The following is a description of a gene set: from publication Delacroix L, Moutier E, Altobelli G, Legras S, Poch O, Choukrallah MA, Bertin I, Jost B, Davidson I (PMID 19884340) Mouse Gene Set: DELACROIX_RAR_BOUND_ES species: Mus musculus Genes with DNA sequences bound by RARA and RARG in ES cells. All-trans retinoic acid (RA) induces transforming growth factor beta (TGF-beta)-dependent autocrine growth of mouse embryonic fibroblasts (MEFs). We have used chromatin immunoprecipitation to map 354 RA receptor (RAR) binding loci in MEFs, most of which were similarly occupied by the RAR alpha and RAR gamma receptors. Only a subset of the genes associated with these loci are regulated by RA, among which are several critical components of the TGF-beta pathway. We also show RAR binding to a novel series of target genes involved in cell cycle regulation, transformation, and metastasis, suggesting new pathways by which RA may regulate proliferation and cancer. Few of the RAR binding loci contained consensus direct-repeat (DR)-type elements. The majority comprised either degenerate DRs or no identifiable DRs but anomalously spaced half sites. Furthermore, we identify 462 RAR target loci in embryonic stem (ES) cells and show that their occupancy is cell type specific. Our results also show that differences in the chromatin landscape regulate the accessibility of a subset of more than 700 identified loci to RARs, thus modulating the repertoire of target genes that can be regulated and the biological effects of RA., and this is the list of marker genes: Oas2, Spint4, Gadd45g, Disc1, Ddit3, Zfp219, Tspan9, Mbd6, Zfp523, Emc10, Mapk1ip1, Rai1, Stra8, Sdha, Ubxn2a, Zic5, Bcat2, Hspb8, Pim3, Spry2, Acp6, Smap2, Otud5, Slc12a7, Dact2, Kdm6b, Tctn1, Cyb5rl, Pgpep1 (NCBI Gene Id 66522), Ndufa4l2, Pcgf1, Peg12 (NCBI Gene Id 27412), Ier2, Tmem135, Wnt1, Inha, Pdpn, Zswim1, Amacr, Rasl10b (NCBI Gene Id 276952), Arg1, Ppdpf, Csf2ra, Rbks, Hivep3, Ppp1r14b, Pdgfrb, Cox17, Alpl, Hmbs, Purb, Trh, Foxp4, Tmem63c, Fgf8, Foxa1, Fgf4, Pick1, Zfp438 (NCBI Gene Id 77367), Hadh, Bcl3 (B cell leukemia/lymphoma 3), Glra2, Kat7, Lin28a, Mbd3, Dennd10, Tmem60, BC048679, Pyroxd1, Lim2, Slx1b, Aebp2, Rxrb, Cryzl2, Pou5f1, Src, Atp11b, Rtbdn (NCBI Gene Id 338533), Cfap20dc, Pimreg, Zc3h3, Nfib, Trim16, Mafa, Kit, Resf1, Agpat3, Fgf1, Aipl1 (aryl hydrocarbon receptor-interacting protein-like 1), Sdk1, Mettl27, As3mt, Spata33, Inppl1, Lefty2, Cnot9, Gja1, Adgrg5, Hlf, Wdr91, Vwa8, Grtp1, Klhdc7a, Fxn, Lefty1, Pidd1, Serpinf2, Gca, Tyrobp, Bmt2, Eif3l, Atxn2, Cpsf4l, Actn4, Ctsd, Skil, Rnf125, Gask1b, Prag1, Cimip2c, Csn3, Lrrc2, Wsb2, Zfp280b, Cidea, Ghdc, Dcaf4, Nacc2, Nbl1 (NBL1, DAN family BMP antagonist), Hyal1, Wfdc2, Slc9a8, Stk35 (serine/threonine kinase 35), Sepsecs, Ubap1, Rhbdd2, Phc1, Vars1, C1qa, Dyrk3, Top2b, Cd37, Tle5, Cog6, Brwd1, Junb, Lsr, Sntb2, Cebpa, Fam91a1, Adgre5 (NCBI Gene Id 26364), Farsa, Gli1, Set, Iqgap3 (IQ motif containing GTPase activating protein 3), Wee1, Klf2, Tcf7l2, Pdcl3, Rps8, Snap25, Tmeff1, Ccp110, Zmiz1, Lactb2, Gpc4, Cystm1, Thnsl2, Rbm14, Tcf19, Kank3, Cdx1, Mok, Gspt2, Gsr, Gprc5a, Eva1b, Ccn2, Spp1, Plekhb1, Fubp3 (far upstream element (FUSE) binding protein 3), Ptprf, Wiz, Rhox11, Pdlim1, Porcn, BC028528, Spc25, Smyd1, Gtf2h1, Mycn, Atg4d, Masp2, Notch4, Zfp64, Med21, Dleu7, Cfap91, Mtss1, Ptpn6, Zfp770, Msh6, Hrob, Rmnd5b, Maco1, Dusp4, Slamf8, Calr, Dhrs3, Lrrc75a, Aanat, Hnrnpab, Insyn1, Fem1b, Nhlh2, Fam25a, Hoxb13, Krt79, Plk3, Mis18bp1, Fam120c, Bckdha, Rhd, Hsd17b14, Itga5, Igfbp2, Jam2, Itpr1, Tafa4, Megf11, Meis2, Hoxa5, Wrap53, Hbegf, Prmt8, Tmprss6, Reep3, Folr1, Zfyve28, Pou2f3 (NCBI Gene Id 18988), Ube2o (ubiquitin-conjugating enzyme E2O), Ncor1, Ifitm2, Cenpm, Idh3b, Steap3, 1700013G24Rik, Tmem127, Pigl, Mybl2, Ints3, Atf3, Rhoq, Uqcrc1, Trim28, Cst3, Dusp1, 2610528J11Rik, Cln8, Tvp23b, Hs3st3b1, Lipe, Dnajb6, Nr6a1, Gpatch3, Fam32a, Msln, G6pc2, Gmnn, Celsr3, Camk1d, Krcc1, Rnf5, Gde1, Ap5s1, H1f2, Agtrap, Rreb1, Pla2g10 (NCBI Gene Id 26969), Col4a1, Srsf6, Ebf4, Utf1, Plcb3, Car4, Slc7a15, Ubxn8, Pef1, Aym1, Tex21, Tmem253, G0s2, Zfp710, Lgi2, Tcl1, Smarcd1, Rb1cc1, Gm867, Atg14, Hoxa4, Muc1, Rab8a, Adgra2, Efna1, Atp2a2, Dedd, Rps15a, Pcgf2, Mdk, Srp14, Rab10, Mrpl51, Itpk1, Mgat3, Apobec2, Lrrc61, Gnl3l, Trim17, Trim7, Mobp, Enah, Kcnc1, Rita1, Mthfd1, Oxnad1, Slc28a1, Pth1r, Rin2, Tcp11, Spred1, Ywhag, Stmn2, Spen, Mylpf, Dph3, Gipc2, Clpb, Dennd2c, Enpp4, Trp53, Ctsz, Ackr3, Gabbr1, Sulf2, Gtpbp4, Dppa5a, Cops6, Uck1, Stat4, Sh3bp1, Shisa5, Msi2, 2410137M14Rik, Cxcr3, Abcb8, Mreg, Sdhd, Dusp9 (dual specificity phosphatase 9), Twf2, Brsk1, Zrsr2, Ppp5c, Slc35f2, Gpa33, Ccnd1, Grhl3, Pik3ip1, Txlng, Sbno2, Polr1a, Slc25a51, Creld1, Fignl1, Camk1, Gbx2, Socs3, Hoxb4, Fhip2a, Mrpl37 (mitochondrial ribosomal protein L37), Cobl, Ankrd28, Slc4a9, Rbpms, St3gal3, Gch1, Fbxo15, Ccdc102a, D630039A03Rik, Gdf3, Cfap161, Mbp, Ntng2, Parvb, Ppp1r10, Barhl1, Il3ra, Otud7b, Cstdc1, Rab20, Upp1, Rarb, Slc35d1, Mief1, Nanos3, Agpat1, Rasal3, Cripto, Rhof, Hoxb1, Mtg2, Ptch1, Nek2, Amt (NCBI Gene Id 434437), Rif1, Ect2, Pbx2, Sall2, Gfod1, Gse1, Eva1a, Bmp4, Ppp1r15b, Mme, S1pr2 (sphingosine-1-phosphate receptor 2), Rbm41, Slc15a1, Dnajc22, Eras, Nudt4, D630003M21Rik, St6galnac6, B3gnt7, Agtpbp1, Tm7sf3, Zeb2, Vat1, Zfp57 (zinc finger protein 57), Sigirr, Fn1, Pdk1, Alkbh7, Ifitm1, Dennd2d, Arf4, Rbp1, Dag1, 4921517D22Rik, Spire2, Ldhb, Atp5f1e, Fam171b, Mdm2, Tlx2, Nr0b1, Anp32a, Pak5, Spred2, Zic2, Stk11, Babam2, Slc39a14, Akap1, Aqp3, Bhlhe40, Cfl2, Mcl1, Ksr1, Capns1, Nodal, Plxdc1, Ing1, Cdh1